Given this list of marker genes Nkx2-5, Tbx2, Wnt3a, Tbx5, Tbx18, Rbpj, Acvr1, Tbx3 (NCBI Gene Id 52240), Fgf10, Mef2c, Myl2, Wt1 (NCBI Gene Id 319408), AW551984, Tbx1, here is a description of the gene set: studied in species Mus musculus The process in which the cellular identity of muscle cells is acquired and determined. Mouse Gene Set: GOBP_MUSCLE_CELL_FATE_COMMITMENT